Given this list of marker genes SUDS3, MACROD1, NDST2, HDAC11, SIRT4, CES1, HDAC4, AADAC, SKI, YDJC, HDAC10, HOPX, NDST1, MIER3, HDAC1, TP53, HDAC2, HDAC6, HDAC9, HDAC8, ING2, HDAC5, SIRT2, HDAC7, AMDHD2, MAPK8, UCN, NDST3, SIRT6, SIRT3, HDAC3, SIRT5, ADPRS, MACROD2, SIRT7, MIER1, MTA2, NDST4, OARD1, CES2, MIER2, PIGL, ESD, SIRT1 (sirtuin 1), here is a description of the gene set: Catalysis of the hydrolysis of an acetyl group from a substrate molecule. studied in species Homo sapiens Human Gene Set: GOMF_DEACETYLASE_ACTIVITY